Given this list of marker genes UPB1, LGALS1, SNX5, PTGR1, PCGF2, EIF3K, NKIRAS2, EBI3, LGALS9B, BORCS7, EDEM2, INO80C, HSCB, THAP11, PDLIM2, SMIM3, S100A13, UBE2J2, EIF2A, ADGRE1, SSBP3, APLP2, UQCC3, SRI, TRIM25, CUZD1, GLRX5, BAD, TEN1, SPCS1, POLR1E, ETV1, CIBAR1, PPIB, PMM1, ABHD17A, PPIL1, C1D, DLEU7, GTF3A, CDC25A, BATF3, WDFY1, DKK2 (dickkopf WNT signaling pathway inhibitor 2), GPAT3 (NCBI Gene Id 84803), REEP5, ST7, RPL39L, C8G, PMEL, UNC119B, DDT, MRPS7, LGMN, ABRA, ABI1, COX8A, TG, SELENOP, PHACTR2, UBE2M, ARPC4, ARMC3, ANKRD37, NAA38, TMEM50A, DOK1, PTPRN, SSR1, CKB, ANK2, TMEM234, ARL8B, SLC35F5, GNA15, PIGX, LEPROTL1, C6orf118, DEDD, NUDT17, ACVRL1, HADHA, RWDD2B, RNF138, GNPDA1, BRI3, TXN2, EVA1B, SEC14L1, PYCARD, SOBP, CNRIP1, CCR5, CD99, MVD, LVRN, BIN3, SLPI, RTCA, PCP4, LZTFL1, ZNF414, KRT222, GPCPD1, RAB11A, MAIP1, HEPACAM2, VHL, MGST2, CXCR3, CUEDC2, ANAPC16, ALDOC, IFI27L2, HIVEP3 (HIVEP zinc finger 3), GLIPR1, PLGRKT (plasminogen receptor with a C-terminal lysine), EDEM1, E2F2, LAT2, CD2BP2, TOMM7, ALOX5AP, TMEM70, DHRS1, TPGS1, PRELID3B, CPT1C, ROPN1L, GNG10, PCYT1A, RTCB (NCBI Gene Id 51493), RAB19, MSRB2, CIR1, TNNI2, QSOX1, MRPL43, ZCCHC9, NDUFA13, ALDH2, RRAGC, S100A4, PROCR, ZNF667, CCDC12, SELENON, SORD, SUPT4H1, TBC1D15, SNF8, RNF7, RPL41, PALM, TWSG1, TNFRSF17, NIT2, SYNGR2, UQCRFS1, SUSD1, SNAP23, PREX1, MCUB (mitochondrial calcium uniporter dominant negative subunit beta), SLAMF6, SLC25A19, SURF1, SLC15A3, VAV3, PPFIA4, CSF2RA, IGLC7, DHRS3 (NCBI Gene Id 9249), PHAX, BATF, SNAP29, IGBP1, ATP8B2, HPSE, BDH1, MFSD10, ITGAM, GSTT2, GPX7, CAPZB, LIFR, NECAP1, ITGA8, PLXNB2, SLC39A11, ALG5, OXLD1, ESD (esterase D), ARPC1B, SEC61A1, RPS27L, GMFG, CLCN5, NCBP2AS2, TMED3, MRPS16, here is a description of the gene set: Th1 and Th2 cells arise from a common precursor cell in response to triggering through the TCR and cytokine receptors for IL-12 or IL-4. This leads to activation of complex signaling pathways, which are not known in detail. Disturbances in the balance between type 1 and type 2 responses can lead to certain immune-mediated diseases. Thus, it is important to understand how Th1 and Th2 cells are generated. To clarify the mechanisms as to how IL-12 and IL-4 induce Th1 and Th2 differentiation and how TGF-beta can inhibit this process, we have used oligonucleotide arrays to examine the early polarization of Th1 and Th2 cells in the presence and absence of TGF-beta after 0, 2, 6 and 48 hours of polarization. species: Homo sapiens Human Gene Set: GSE2770_UNTREATED_VS_ACT_CD4_TCELL_6H_UP from publication Lund R, Aittokallio T, Nevalainen O, Lahesmaa R (PMID 14607935) Genes up-regulated in CD4 T cells: untreated (0h) versus activated by anti-CD3 and anti-CD28 (6h).